The following is a description of a gene set: Decreased CD8+ T cell proportion Abnormal decrease of cytotoxic CD3+CD8+ T cells, measured as percentage of total CD3+ T cells in the blood, compared to a reference range for a given sex and age-group. These are usually measured within the TCR alpha/beta positive population. species: Homo sapiens Human Gene Set: HP_DECREASED_CD8_T_CELL_PROPORTION, and this is the list of marker genes: IL2RG, ZAP70, NSMCE3, CD8A, CD3G, WAS, IKBKB, WIPF1, PIK3CG, IL7R, EXTL3